The following is a description of a gene set: from publication Xie X, Lu J, Kulbokas EJ, Golub TR, Mootha V, Lindblad-Toh K, Lander ES, Kellis M (PMID 15735639) Human Gene Set: CGTSACG_PAX3_B species: Homo sapiens Genes having at least one occurrence of the highly conserved motif M70 CGTSACG in the regions spanning 4 kb centered on their transcription starting sites. This matches the PAX3 transcription factor binding site V$PAX3_B (v7.4 TRANSFAC). Comprehensive identification of all functional elements encoded in the human genome is a fundamental need in biomedical research. Here, we present a comparative analysis of the human, mouse, rat and dog genomes to create a systematic catalogue of common regulatory motifs in promoters and 3' untranslated regions (3' UTRs). The promoter analysis yields 174 candidate motifs, including most previously known transcription-factor binding sites and 105 new motifs. The 3'-UTR analysis yields 106 motifs likely to be involved in post-transcriptional regulation. Nearly one-half are associated with microRNAs (miRNAs), leading to the discovery of many new miRNA genes and their likely target genes. Our results suggest that previous estimates of the number of human miRNA genes were low, and that miRNAs regulate at least 20% of human genes. The overall results provide a systematic view of gene regulation in the human, which will be refined as additional mammalian genomes become available., and this is the list of marker genes: SLC6A12, PEX11G, RELB, SPINK5, ZBTB20, ZEB2, RAB7A, SUPT16H, NUBPL, EVA1C, BCL11A, PPP2R1A, RNF146, GEM, TEX14, AFF4, SLC25A3, HMOX2, HOXA9, RAD51C, GTF2H1, RFT1, SLC38A2, WDR81, SLC18A2, ARFGEF1, RBM18, IRX6, ALKBH5, FAM217B, POLB, CDKN1A, DCAF11, BHLHE40, ELOVL5, EMSY, CTCF, CDC14B, RAD9A (NCBI Gene Id 5883), EGR1, PDXDC1 (NCBI Gene Id 23042), FOXD3, STXBP1, EGR3, CASK, PEPD, PTMA, GYG1, NAB2, RBBP8, MFSD5, CBX6, YME1L1, NOL4, TSC22D2 (NCBI Gene Id 9819), CYB5D2, MRRF, PIAS4, NMRAL1, USP8, PHLPP1, IKBKB, EIF4E, DHX36, C1orf43, VPS37B, SMARCA5, PHACTR3, SOAT1, GNAS, CUL5, PLEKHH3, PCNP, LYPD1, HMGN1, CMTR1, AKIRIN1, EGR2, PNRC1, EGR4, PLK2, MINK1, BRAF, KAT5 (lysine acetyltransferase 5), XBP1, HABP4, ANKHD1-EIF4EBP3, PPP1R3D, MTHFD1L (NCBI Gene Id 80244), GGA1, PITX2 (paired like homeodomain 2), ANKHD1, CANX, JOSD2, PPT2, ANKS1A, TSPYL5, DBF4, PTPN23, HPS5, GLYR1, TMEM165, LTBP1, PBRM1, PDPR, NRK, HOXC10, PELI3, PDP1, CRY1, CHGB, SULT4A1, PDZD7, RASD1, GK, MAB21L1, EN2, SKIDA1, ZZZ3, ADAM10, YJU2B, WSB1, PAK2, EHD4, NKX2-3, ZFY, NR4A1, NEUROD2, SLC25A40, EPC1, EDEM1, GJD2, SLC25A33, NSRP1, NR4A2, IPO7, ZNF711, SMARCE1, KCNE4, AP2B1, MIR22HG, MASTL (NCBI Gene Id 84930), NDUFB2, TRIB1, GIGYF2, TAF11, ZZEF1, BCL11B, VPS26A